Given this list of marker genes CD63, CHMP3, HGS, NEDD4L, ECPAS, CRHBP, TSG101, SFTPC, SFTPA2, HDAC6, ZP2, ATP13A2, STEAP3, CHMP6, SORL1, CHMP1B, CD79A, VTA1, TMEM9, ABCA3, ACP3, NDFIP2, CHMP4A, CD74, ARAP1, SFTPA1, RAB27A, CST7, PMEL (NCBI Gene Id 8088), NSG2, CTSH, GIMAP5, ABCB6, CHMP4BP1, PGA4, MBL2 (mannose binding lectin 2), PRKAR1B (NCBI Gene Id 645590), SLC2A4, CHMP5, CHMP7, APOE, LRRK2, SLC17A8, CHMP1A, LAPTM4B, SFTPD, LRAT, TPT1 (NCBI Gene Id 7178), PGA5, CD300LG (CD300 molecule like family member g), CHMP2A, CHMP4C, BACE1, NAPSA, PGA3, SFTPB, SLC9A8, NSG1, CHMP4B, CHMP2B (charged multivesicular body protein 2B), BST2, RAB27B, CTSL, PRKAR1A, LAMP1, GFRA1, EGFR, RAB11A, here is a description of the gene set: species: Homo sapiens A type of endosome in which regions of the limiting endosomal membrane invaginate to form internal vesicles; membrane proteins that enter the internal vesicles are sequestered from the cytoplasm. Human Gene Set: GOCC_MULTIVESICULAR_BODY